The following is a description of a gene set: from publication Chen Y, Wang X (PMID 31504780) species: Mus musculus Mouse Gene Set: MIR_27A_3P_MIR_27B_3P Genes predicted to be targets of miRBase v22 microRNA mmu_miR_27a_3p, mmu_miR_27b_3p in miRDB v6.0 with MirTarget v4 prediction scores > 80 (high confidence targets)., and this is the list of marker genes: Pappa, Amotl2, Stx16, Mtss2, Tlk2, Aff4, Pdlim5, Arhgap12, Car10, Colgalt2, Ppm1k, Ro60, Insm2, Dram2, Dlk1, Neurl1b, Mtcl2, Frmd6, Anks1, Larp4, E130308A19Rik, Hlx, Ech1, Eya1 (EYA transcriptional coactivator and phosphatase 1), Hmgcr, Zbtb34, Trappc8, Nxt2, Fam193b, Rgs8, Zbtb33, Nfe2l2 (nuclear factor, erythroid derived 2, like 2), Ing5, Gng12, Kat2b, Cdk18, Foxp4, Rbbp6, Cep135, Rpgrip1l, Chst2, Plxnd1, Ampd3, Gcc2, Pikfyve, Fam98a, Kcnk5, Mrps12, Epb41, Cyp39a1, Cipc, Appbp2, Prpf39, Slitrk1, Ccny, Nrbf2, AU040320, Elfn2, St14, Onecut2, Nrep, Btg2, Spry2, Abl2, Bmi1, Creb1, Map2k4, Ncald, Rapgef2, Atp11c, Vav2, Kcnj13, Hsp90aa1, Ccnc, Xpo1, B3gnt7, Fut9, Gpr174, Tnrc18, Galnt1, Nemp1, Edil3, Pcnx1, Ccm2, Nlk, Pax9, E2f7, Tab3, Myt1, Zbtb10, Zkscan4, Flrt3, Foxo1, Glra2, Ankrd42, Prrg3, Sema6a, Adam19, Sema7a, Stk38, Lonrf1 (NCBI Gene Id 244421), Ercc6l, Wee1, Styk1, Ckap4, Mknk2, Fzd4, Asph, Zmat3, Rsad2, Tgfbr3, Pla2g4e, Rab14, Tmem140, Rab11fip1, Lox, Cacng2, Runx1, Cabp1, Cdc25b, Pnkd, Ikzf1, Dnajc3 (NCBI Gene Id 19107), Plcxd2, Tbpl1, Cpne8, Tor1b, Fbxw7, Galnt7, En2, Akirin1, Efna4, Mrps14, Gxylt1, Cdh11, Ube2w, Pigc, Ncapd3, Tril, Maoa, Szrd1, Ss18l1, Ptgdr, Gpc5 (glypican 5), Ntn1, Plk2, Clcn3, Npas3, Otx2, Tmem91, Nrip1, Dtna (NCBI Gene Id 68022), Rbpms2, Mstn, Dnajc27, Mmd, Hook3, Slco2b1, Epb41l4a, Zfhx3, St6galnac3, Kcnj3, Gltp, Rgs1, Ncoa5, Csrp2, Zfp959, Spty2d1, Ogn, Afap1, Cds1, Slc26a2, Nemp2, Tmbim6 (NCBI Gene Id 68309), Nr1d2, Pdgfra, Gria4, Fam133b, Vdac3, Slco5a1, Zfp143, Fam76b, Bltp1, Prkcb, Sowaha, Galnt3, Wnk2, Fosb, Zfp800, Zbtb42, Klhl31, Csrnp1, Rps6kb1, Frs3, Cpeb3, Pparg, Gata2, Unkl, Rfpl4, Mrps31, Epb41l1, 2410004B18Rik, Rasgrf2, Slc25a44, Dzank1, Reps1, Kpna3, Ugt8a, Sfrp1, Cysltr1, Pde3b, Grb2, Plppr1, Matn3, C2cd2, Shroom2, Grm5, Npepps, Kdm3a, Slc35a3, Gns, Omt2a, Strbp, Arrdc4, Rxra, Brsk1 (BR serine/threonine kinase 1), Pakap, B4galt3, Tnrc6b, Fzd7, Litaf, Enox2, Mal2, Pdzk1ip1, Tead1, Abhd17b, Pira2, Zbtb39, Nrarp, Pnrc1, Patz1, Cdip1, Ppp1cc, Ugcg, Dot1l, Man1a, Usp42, Lratd2, Phb1, Capza1, Gosr2, Pla2g6, Gfpt2, Plcl2, Fam91a1, Kcnn3, Chka, Vps13a, Dnajc5b, Cth, Plpp3, Ube2n, Itsn2, Nr2f6, Pdia5, Ino80d, Stag1, Atp2b1, Rnf144a, Psma1, Kpnb1, Rreb1, Slc35f1, Trim23, Tbr1, Slc6a1, Pkia, Arx, Ifng, Suco, Tppp, Ccnj, Hbegf, Edrf1, Zfp148 (zinc finger protein 148), Ube2v1, Pclo, Med12l, Ppara, Rnf139, Rsbn1l, Dst, Cables2, Dipk1a, Marchf6, Radx, Lpar6, Clk2, Sema4c, Nabp1 (NCBI Gene Id 98468), Abhd17c, Tsc22d2, Ppp1r1c, Tet1, Nrk, Rmnd5a (required for meiotic nuclear division 5 homolog A), Gmps, Arhgap1, Aldh5a1, Inpp5j, Mier3, Dcaf12, Cbfa2t3, Serpini1, Smad9, Zfp597, Klhdc3, Dkk2, Slc25a25, Satb2, Fn3krp, Zcchc24, Fbxo30, Sim1, Necap1, Fam184a, Retreg3, Unc13c, Vav3, Hsdl1, Chd7, Mbtd1, Tnpo1, Hip1, Naa15, Rictor, Rora, Cdh5, Nr5a2, Pard6b, Crebrf, Aqp11, Nav2, Qki, Pds5b, Edem3, Map2k7, Adamtsl3, Hapln1, Pgm2l1, Nr2f2, Polr1f, Erg, Slc7a11, Add1, Phlpp2 (PH domain and leucine rich repeat protein phosphatase 2), Arpp21, Sgpp1, Kctd8, Plekhh1, Ccdc28b, Elavl2, Ripor2, Raph1, Sik1, Poglut1, Abcb9 (NCBI Gene Id 56325), Tmem240, Mmp16, Acer2, Pik3ca, Usf3, Nrp2, Nkain1, Slc34a2 (solute carrier family 34 (sodium phosphate), member 2), Pom121, Edem1, Pdhx, Herc3, Sval3, Lifr (LIF receptor alpha), Tmcc1, Zhx1, Cog6, Dll4, Peli2, Hoxa5 (homeobox A5), Cavin2, Paqr9, Efnb2, Arfgef1, Usp25, Hic1, Tmem170b, 1600012H06Rik, Utp23, Neurl4, Hcn4, D3Ertd751e, Ppif, Brpf3, Hyou1, Hycc2, Apaf1, Adora2b, Rpf1, Scn9a, Ngfr, Acly, Gata3, Cacna2d3, Il7r, Peak1, Stk39, Gpd2, Kcnk2, Ncam1, Atad2b, Kmt5b, Abca1, Slc35f4, Mdn1, Smoc2, Wbp2, Hoxa10, Ehf, Ubr5, 1700025G04Rik, Mccc2, Adcy6, Map1b, Wnk3, Usp46, Wsb1, Klhl29, Psen1, Acvr1c, Arhgef37, Gria3, Dcun1d4, Nxf1, Heg1, Magi3, Eepd1, Med14, Zfp462, Ccnk, Rara, Limk1, Txlng, Mdm4, Prkaa2, Seh1l, Sos1, Wipf2, Csf1, Cecr2, Gspt1, Agrn (NCBI Gene Id 381587), Erlec1, Rbfox1, Bltp3a, Spata13 (NCBI Gene Id 30870), Fam78a, Kmt2c, Neurod6, Alkal2, Map3k14, Mdfi, Wdr37, Adamts10, Shc4, Bend4, Rufy3, Gab1, Snap25, Brwd1, Pgbd5, Oaf, Sox11, Nipal4, Ubp1, Sema6d, Dnajc13, Lpin1, Golm1, Omt2b, Clcn5, Kbtbd8, Rcor3, Cacnb2, Hdx, Arhgef26